The following is a description of a gene set: from publication Chen Y, Wang X (PMID 31504780) Genes predicted to be targets of miRBase v22 microRNA mmu_miR_7088_5p in miRDB v6.0 with MirTarget v4 prediction scores > 80 (high confidence targets). species: Mus musculus Mouse Gene Set: MIR_7088_5P, and this is the list of marker genes: Zbtb21, Tbl1xr1, Fsd1l, Tnfrsf22, Atrx, Avl9, Dnase1l3, Phf20l1, Qki, Arpc2, Apcdd1, Ddit4, Itga1, Eif1b, Itpr1, Il23r, Tmem135, Dock3, Tnks1bp1, Elf4, Lhfpl2, Tnfrsf23, Epb41l3, Vegfd, Nr5a2, Bag4, Abt1 (NCBI Gene Id 30946), Scn2a, Itprip, Ankrd17, Mfsd6, Ankrd34a, Zmym3, Hook3, Rapgef2, Yod1, Faxc, Ppp4c, Casz1, Ddx6, Itsn2, Tmem263, Ssh2, Lzts2, Serpinc1, Trpc6 (NCBI Gene Id 22068), Sh3pxd2a, Ugt2b5, Timm22 (NCBI Gene Id 80476), Igsf1, Slitrk5, Ptbp1, Rap1gap2, Spdye4a, Trim33 (tripartite motif-containing 33), Mex3c, Esr2, Adam9, Vxn, Nufip2, Elf1, Ptp4a2, Slc6a6, Bcl11a, Ccdc137, Ero1b